The following is a description of a gene set: studied in species Mus musculus Any process involved in the carrying out of an immune response by a T cell. Mouse Gene Set: GOBP_T_CELL_MEDIATED_IMMUNITY, and this is the list of marker genes: Raet1d, Map3k7 (NCBI Gene Id 93774), P2rx7, H2-Q2 (histocompatibility 2, Q region locus 2), C4bp, Crlf2, Lilrb4b, B2m, H2-M5, Tnfsf4, Nfkbiz, H2-Q4, H2-M9, Traf6, Cd81, Stx7, Arid5a, Ccr2, Jag1, Cd55b, H2-T24, Il4i1, Il31ra, Lilrb4a, Il18r1, Dpp4, H2-M10.2, Nectin2, Arg1, Kdelr1, Slfn2, Il18rap, H2-Q1, H2-M10.4 (NCBI Gene Id 333720), Hspd1, Cdh17, Il18, Xcl1, Zp3, Ywhag, Dlg1, Aire, Ceacam1, Trpm4, Il25, Muc4, Zbtb1, H2-M2, Clec4g, Ebag9, Dennd1b, H2-Q10, Foxp3, Ccl20, Ufl1, Tbx21, H2-M10.3 (NCBI Gene Id 386452), Stx11, Ctsh, H2-D1, Il23a, Ripk3, Il20rb, Klrd1, Fzd5, Raet1e, Fcgr4, Tnfrsf1b, Cd24a, Cr1l, Kdm5d, H2-M1, Ager, Cd70, Hfe, Ulbp1 (UL16 binding protein 1), Ahr, Vsir, Treml4, H2-T5, Slc22a13, Gfus, Ppp3cb, Fbxo38, Myo1g, Rab27a, Il6, Sash3, Serpinb9, Nod2, Nckap1l, Prkaa1, Unc93b1, Gata3, Hmgb1, Cyrib, H2-M3, H2-M10.5, Mill1, Cd46, Was, Il7r, Klhl22, Tap2, H60c, Il1b, Slc11a1 (NCBI Gene Id 18173), H2-M11, Pvr, Malt1, H2-M10.1, Hprt1, Il12a, Serpinb9b, Pnp, Zp3r, H2-Q7, Cd80, Cd1d2, H2-Ea, Gzmb (granzyme B), H2-T15, Ctsc, Ephb6, Ptprc, Cd274, Cd55, Lyst, Dusp22, H2-M10.6, Stard7, H2-Q6, Il12b, Slamf1, H2-T13, 2410137M14Rik, Cd8a, H2-T3, Mr1, Traf2, Prkcz, Icam1, Rsad2, Trex1, Fadd, Gzmm, Il1r1, Nlrp3, Cr2, Smad7, H2-T23, H2-T22, Il4, Azgp1, Fut7 (fucosyltransferase 7), Gba1, Rftn1, H60b, Pdcd1, Prf1, Ifnb1, Hspa8, Fosl2, Emp2, Cd1d1, Spn, H2-K1